Given this list of marker genes CATSPERB, CUTC, ENSG00000223438, DYM, CDH11, HSPA12A, RFPL2, NDST4, SART3 (NCBI Gene Id 9733), CFAP97D1, FGF11, ABCG2, LDLR, TLCD3A, CFAP300, MMP16, ALAS1, RANBP10, DUX4L8, SOX17, MGLL, PNPLA8, ZNF775, PRDM10-DT, AOX1, LCA5L, PCDHB16, SCN5A, CYB5B, SLC9B2, SLC38A11, FNDC4, ARMCX5, TOB1, HDX, ZNF277, DHX38, CRACR2B, SMOC1, UBE2DNL (NCBI Gene Id 340561), AIFM1, SERINC3, MRPL51, RPS15, ARHGAP42, OOSP2, NRIP2, BAZ2A, ZBTB37, MLH3, SP3P, ZNF250, KCNG3, SIK3, DPY19L1, PSG1 (NCBI Gene Id 91730), AHCYL1, GREM2, PSMC3, PLEKHG6, CD99L2, POP7, CPS1, LRP12 (NCBI Gene Id 80002), PLA2G4D, LPAR3, DAAM2, MAP2K4, DDX27, SERBP1, SP1, PROKR2, PCGEM1, FBXO45, NR1H3, CSNK2A2, PKHD1, TAF1A, CIZ1, BEND7, CNTN3, SUMO2, CHRAC1, NLGN1, SLC25A2, CXXC4, DAPK3 (NCBI Gene Id 1613), TACO1, GUCD1, CALCRL, B3GALT2, SIX6, ENSG00000277182, ADAM7, ATP6V1G1, NOX4, HMGB3P22 (high mobility group box 3 pseudogene 22), ENTREP1, GPR63, SLC24A2, PASD1, HJV, TMEM50A, CPD, LIMS2, GPD2, EQTN, LINC00899, CP, IFNA21, MSLN, ANKFN1, ZNF169, TRIM31, RNLS, ANXA5, SPATA45, FAM229A, ZXDB, ALDH1L2, NPIPB3, TMEM225B, UPK1B, CT83, NPPA, AGO3, KCNC2, TCEANC2, CLTB, ABCF3, GNMT, CSN1S2AP, SEMA4A, AKT3, SCN11A, SPATS2L, PPP4R1L, PTEN, KLF17, USP11, BUD23, DNAJB11, MARK2, PRKCH, MS4A6E, LHX6, FOXE3, NRL (NCBI Gene Id 4901), PDIA3, CCNYL2, LINC00919, SRP68, RPS14, C5orf22, TM6SF2, TRAF6, LINC01592, NDUFS4, IRGC, MYLK, FXR1, EPRS1, LINC00189, DGKI, SEPTIN7P9, RNF6, SLC10A1, NR1D2, TTTY7, COPG1, DOK7, SLC7A6OS, BLOC1S4, ARSL, ROPN1, RFWD3, ZNF324, ATP5MC2, C16orf78, OR5J2, SLITRK1, CDH19, PIK3CG, PLEKHG1, MSI1, POSTN, TMPRSS6, LCP1, TPSG1 (NCBI Gene Id 25823), KIF2B, DNAH14, ESYT3, here is a description of the gene set: from publication Schenk M, Krutzik SR, Sieling PA, Lee DJ, Teles RM, Ochoa MT, Komisopoulou E, Sarno EN, Rea TH, Graeber TG, Kim S, Cheng G, Modlin RL (PMID 22447076) studied in species Homo sapiens Human Gene Set: GSE34156_NOD2_LIGAND_VS_NOD2_AND_TLR1_TLR2_LIGAND_24H_TREATED_MONOCYTE_UP Genes up-regulated in monocytes (24h): muramyl dipeptide versus muramyl dipeptide and M. tuberculosis 19 kDa lipopeptide. human blood monocytes were isolated, activated and harvested at several timepoints In this study, we identified genes that were differentially expressed in human monocytes activated with eiter NOD2L and/or TLR2/1L.